Given this list of marker genes ADRB1, NOS1, NPPA, GPER1, DRD1, MAS1, MKKS, EXT2, MRGPRD, KNG1, RGS2, BBS2, BDKRB2 (bradykinin receptor B2), ITGA1, PTPN11, ADORA2B, F2RL1, AGTR2, INS, APOE, ABCC9, VSTM4, SOD1, GUCY1A1, MIR138-1, ADRB3 (adrenoceptor beta 3), GAB1, CALCA, TNF (NCBI Gene Id 7124), VEGFA, PPARD (peroxisome proliferator activated receptor delta), KAT2B, EXT1, PRKG1, ADORA2A, BLOC1S6, NOS3, GJA5, ATG5, S100A1, ADORA1, IRAG1, CPS1, NPPB, KCNMA1, KLF2, SCARB1, ADRA2A, EDNRB (endothelin receptor type B), SRC, GPX1, PLOD3, SOD2, MIR153-1, ADRB2, CASR, UCN, PECAM1, KCNJ8, here is a description of the gene set: Human Gene Set: GOBP_VASODILATION species: Homo sapiens An increase in the internal diameter of blood vessels, especially arterioles or capillaries, due to relaxation of smooth muscle cells that line the vessels, and usually resulting in a decrease in blood pressure.